Given this list of marker genes MYL1, CHAT, RYR1, TTN, AK9, CHRNB1, DPAGT1, SLC18A3, MUSK (muscle associated receptor tyrosine kinase), VAMP1, SNAP25, ALG14, SLC5A7, ALG2, SPEG (NCBI Gene Id 729871), MYO9A, CHRND (cholinergic receptor nicotinic delta subunit), LRP4, OPA1, CACNA1D, LAMB2, SYT2, DOK7 (NCBI Gene Id 619409), COLQ, AGRN, SCN4A, GFPT1, CHRNE, SLC25A1, BIN1, TEFM, RAPSN, CHRNA1, NOTCH2NLC, COL13A1, GMPPB, here is a description of the gene set: species: Homo sapiens An electromyographic finding associated with erratic or absent neuromuscular transmission with erratic, moment-to-moment changes in the shape of the motor unit potential (MUP). EMG: impaired neuromuscular transmission Human Gene Set: HP_EMG_IMPAIRED_NEUROMUSCULAR_TRANSMISSION